Given this list of marker genes RPS15, RPS27L, RPL17, RPLP1, RPS4X, RPS21, RPL10, RPL31, 5S rRNA, RPS7, RPS18, RPL35, RPL12, RPL19, RPL7A, RPL27A, EEF1D, RPL22, RPS27, RPS12, RPL5, EEF2, RPS2, EEF1A2, RPL6, RPL39L, RPS17, RPL34, RPL39, RPSA, EEF1B2, RPS20, RPS26, RPS27A, RPL38, RPS24 (NCBI Gene Id 6229), 28S rRNA, RPL36, RPL32, RPL23, RPL23A, RPL18A, RPS19, RPL15, RPL3, RPS8, RPL9, RPS11, RPS3, RPL36AL, RPL13, RPS28, RPL24, RPS6, RPL4, RPL30, RPL18, RPS14, RPS15A, RPL28, RPL26, 5.8S rRNA, EEF1G, RPS3A, UBA52, RPS29, RPL7, RPL35A, RPS23, RPL8, RPL37A, RPL36A, RPL10A (NCBI Gene Id 4736), RPL27, RPL21, FAU, RPS4Y2 (NCBI Gene Id 140032), RPL11, RPLP2, 18S rRNA, RPL22L1, RPL3L, RPS4Y1, RPS13, RPL41, RPS16, RPL37, RPS25, EEF1A1, EEF1A1P5, RPL13A, RPS5, RPL26L1, RPLP0, RPL14, RPS10, RPS9, RPL29, RPL10L, here is a description of the gene set: part of: Translation The translation elongation cycle adds one amino acid at a time to a growing polypeptide according to the sequence of codons found in the mRNA. The next available codon on the mRNA is exposed in the aminoacyl-tRNA (aa-tRNA) binding site (A site) on the 30S subunit.<br>A: Ternary complexes of aa -tRNA:eEF1A:GTP enter the ribosome and enable the anticodon of the tRNA to make a codon/anticodon interaction with the A-site codon of the mRNA. B: Upon cognate recognition, the eEF1A:GTP is brought into the GTPase activating center of the ribosome, GTP is hydrolyzed and eEF1A:GDP leaves the ribosome. C: The peptidyl transferase center of ribosome catalyses the formation of a peptide bond between the incoming amino acid and the peptide found in the peptidyl-tRNA binding site (P site). D: In the pre-translocation state of the ribosome, the eEF2:GTP enters the ribosome, physically translocating the peptidyl-tRNA out of the A site to P site and leaves the ribosome eEF2:GDP. This action of eEF2:GTP accounts for the precise movement of the mRNA by 3 nucleotides.Consequently, deacylated tRNA is shifted to the E site. A ribosome associated ATPase activity is proposed to stimulate the release of deacylated tRNA from the E site subsequent to translocation. In this post-translocation state, the ribosome is now ready to receive a new ternary complex.<br>This process is illustrated below with: an amino acyl-tRNA with an amino acid, a peptidyl-tRNA with a growing peptide, a deacylated tRNA with an -OH, and a ribosome with A,P and E sites to accommodate these three forms of tRNA. studied in species Homo sapiens Reactome Pathway: Eukaryotic Translation Elongation